The following is a description of a gene set: Human Gene Set: GSE17721_LPS_VS_PAM3CSK4_16H_BMDC_DN species: Homo sapiens mouse primary BMDCs were stimulated with tlr ligands and gene expression changes were profiled on Affymetrix arrays Genes down-regulated in comparison of dendritic cells (DC) stimulated with LPS (TLR4 agonist) at 16 h versus DC cells stimulated with Pam3Csk4 (TLR1/2 agonist) at 16 h. from publication Amit I, Garber M, Chevrier N, Leite AP, Donner Y, Eisenhaure T, Guttman M, Grenier JK, Li W, Zuk O, Schubert LA, Birditt B, Shay T, Goren A, Zhang X, Smith Z, Deering R, McDonald RC, Cabili M, Bernstein BE, Rinn JL, Meissner A, Root DE, Hacohen N, Regev A (PMID 19729616), and this is the list of marker genes: DHCR24, GPR85, PJA2, PUS7, CLINT1, NPEPL1, ENTPD7, SEC61G, FN1, MAPK13, EVI2B, CD5L, STARD7, WBP2, SEPTIN6 (septin 6), KIF20A, PTPN1, UQCC2, KIRREL1, IGFBP1, MGST1, ADCY9, CD300C, COX6A1, TMEM9B, DHX40, SFXN3, HTR1A, MYADM, PLCG2, ARHGAP31, POFUT2, RAB31, BICC1, LTB4R2, CD37, HJURP, MAST3, TNFRSF21, EFCAB7, CIB2, TMEM119, EDA, TSPAN5, CLEC14A, RPS16, BANF1, CLCN5, SRXN1, ST7, SYNCRIP, PLCB4, AIFM1, CHRDL2, HVCN1, FASN (NCBI Gene Id 2194), RRN3, UPF3B, NCAPD2, SMC4, TXNDC5, EEF1B2, KIF3C, MARCO, MAPK3, RIPOR2 (NCBI Gene Id 9750), RPL37A, GEMIN2, UCP2, WDR4, GDPD3, PAICS, ANXA10, SLC19A2, TBCEL, TIMM10B, CYFIP1, HAGH, SLC12A6, SLC25A39, NCOR2, TMED7, ARHGEF1, NAGK, MMACHC, ID3 (inhibitor of DNA binding 3), CNIH1, LPIN1, DYNLT3, MPO, ABCC6, NDUFB6, STMN1, STK10, RILPL2, PRXL2B, FDPS, INCENP, PDE8A, PYY, HLX, NCKAP5L, GLIPR1, TIAM2, DGAT1, GRIPAP1, RTL8C, RPS9, SMAD4 (NCBI Gene Id 4089), HECTD1, IRAK4, EDNRB, PARP1, PHKB, SEC61B, SNX18, SUSD2, TSPAN12, TGFBR2, PRKAG1, NSDHL, DNLZ, S100A1, TOMM40L, SNCA, MECR, RRP15, IL12A, POMGNT1, PHLDB1, ACOX1, PHKA2, MAP1LC3A, LIMD1, SAYSD1, MRPL23, PI4KA, SMIM7, YBX1, SACM1L, CGA, STK17B, DOCK5, MYL1, LTC4S, DSTYK, APEX1, CAD, HSD11B1, ATP6V0B, PCCB, PRPF6, CENPC, EIF2S3, ANGEL2, DDHD2, NCAPG2, UQCRQ, FADS2, TMEM109, SERF2, ACADM, MEF2A, ALDH6A1, CLIP1, MYO1B, RPTN, EEF1G, ADK, TMED5, DLL3, TMEM135, ZNF704, RBFOX2, OST4, ZYX, RPL3, SREBF2, PABPC4, RIOK2, GM2A (ganglioside GM2 activator), NELFE, DLG1, GUSB, NEK9, PAFAH2, HGSNAT, PGM2, AGTPBP1, AKR1B15, RPS10, BOLA2, KCNK13, SRRT, SIGLEC7, CTDNEP1, C19orf73, EBPL, PGLS, PLPP1